The following is a description of a gene set: studied in species Homo sapiens The initial attachment of a membrane to a target membrane, mediated by proteins protruding from the two membranes. Docking requires only that the membranes come close enough for the proteins to interact and adhere. Human Gene Set: GOBP_MEMBRANE_TO_MEMBRANE_DOCKING, and this is the list of marker genes: VCAM1 (NCBI Gene Id 7412), ICAM1, EZR, MSN, ROCK1 (Rho associated coiled-coil containing protein kinase 1), SELENON